The following is a description of a gene set: Mouse Gene Set: REACTOME_DOPAMINE_RECEPTORS species: Mus musculus Dopamine receptors, and this is the list of marker genes: Drd2, Drd4, Drd5, Drd3, Drd1